The following is a description of a gene set: Regulatory T (Treg) cells that express the FoxP3 transcription factor are essential for lymphoid homeostasis and immune tolerance to self. Other non-immunological functions of Treg cells, such as controlling metabolic function in adipose tissue, are also emerging. Treg cells originate primarily in the thymus, but can also be elicited from conventional T cells by in vivo exposure to low-dose antigen or homeostatic expansion, or by activation in the presence of TGFβ in vitro. Treg cells are characterized by a distinct transcriptional signature controlled in part, but not solely, by FoxP3. For a better perspective on transcriptional control in Treg cells, we compared gene expression profiles of a broad panel of Treg cells from various origins or anatomical locations. Treg cells generated by different means form different sub-phenotypes identifiable by particular combinations of transcripts, none of which fully encompass the entire Treg signature. Molecules involved in Treg effector function, chemokine receptors, and the transcription factors that control them are differentially represented in these subphenotypes. Treg cells from the gut proved dissimilar to cells elicited by exposure to TGFβ, but instead they resembled a CD103+Klrg1+ subphenotype preferentially generated in response to lymphopenia. studied in species Homo sapiens Human Gene Set: GSE20366_EX_VIVO_VS_DEC205_CONVERSION_UP Genes up-regulated in comparison of TregLP versus DEC-Pept Convert (see Table 1S in the paper for details). from publication Feuerer M, Hill JA, Kretschmer K, von Boehmer H, Mathis D, Benoist C (PMID 20231436), and this is the list of marker genes: EPAS1, FZD4, AK7, ZNF189, KHDC1L, UMAD1, CYP2D6, PON2, KLHL9, CXCR6, TLE2 (TLE family member 2, transcriptional corepressor), CHORDC1, FAM111A, AIM2, CIPC, TRIM34, ERO1A, JCHAIN, C18orf54, PSEN1, GLMN, XDH, AFG2B, GCNT1, KIAA1958, SMC2, CDC23, GLCCI1, RCOR3, HOPX, PLPP2, MED23, APOBEC3B, HOMER1, OPTN (optineurin), ALG8, H6PD, CCR5, GPR155, MB, DAW1, SEC14L1, RCBTB2, NBR1, AHR, NEK2, BNIP2, RNF214, PIGL, DENND11, MYNN, DKK3, PARVG, VPS4A, ERMP1, IKZF3, TMEM237, CBX7, B4GALNT4, HMMR, ESAM, CHD9, NSDHL, TAPBPL, MORC1, ACSS2, SAP130, ZNF3, ZNF790 (NCBI Gene Id 388536), HMGXB4, BIVM, CHMP3, TJP2, SDC4, MKNK1, NAGA, MED7, KCTD12, IDI1, MAPK1, KIFBP, FANCF, CORO2A, SYTL2, EFL1, TEC, DCUN1D1, N4BP1, H1-4, FAM151B, SLC25A45, PPIP5K2, ZSCAN12, P2RX4, VILL, GALC, ICA1, PLVAP, HSD17B1, FBXO42, LMAN2L, ARMC8, ZNF839 (NCBI Gene Id 55778), RIN2, IL17RB, MMEL1, INSIG2, NCK1, PADI2, SPCS3, PCDHB1, MAP3K7, SDCCAG8, CCDC51, THUMPD3, ANTXR2, TMEM70, PARP16, FBXL3, ILDR1 (NCBI Gene Id 449482), IPCEF1, METRNL, CMTM7, PCMTD2, GOLPH3L, DCUN1D3, METTL4, TENT5C, SPARCL1, CCR4, UTP6, RACGAP1, ZNF322, ANKRD6, TRAFD1, PLXDC1, TSPAN12, CROT, SSPN, PARD6G, CLCN4, UBE2B, TTC33, LDAF1, FAM156A (NCBI Gene Id 29057), PHETA2, RIGI, GPR15, TMEM18, SLC2A3, BAG2, EPHX4 (NCBI Gene Id 253152), NAV2, FAM120B (family with sequence similarity 120 member B), GPR68, ITPRIPL2, RIMKLA, STX11 (syntaxin 11), CERK, CABLES1, PLCL1, SLC7A6, CKAP2L, TRMT2B, MYO3B, IL10, SHC1, ANG, SLC15A2, CSTF3, HERC1 (HECT and RLD domain containing E3 ubiquitin protein ligase family member 1), FKBP5, PLEKHF1, FAM185A, BLOC1S6, UBE2Q2, PPP6C, EGR3, CWF19L2, RUNDC3A, GDPD5, NDFIP1, CDK20, MYADM, NCKAP5, AGPAT4, RAD17, PNPT1, OSBPL3, ARHGAP11A, TMBIM1, ANGPTL2, IFIT3, ARL14EP, ATP6V0A1, SLC43A2, IL18RAP, WDR12, PEPD